Given this list of marker genes IL12B, ADAMTS12, CADM4, HRG, PIK3CB, MIR199A1, DAB2IP, ANGPT1, SPRY2, MIR16-1, ATP2B4, MIR342 (NCBI Gene Id 442909), MIR424, IL12A, EMILIN1, MIR329-1, SEMA6A, DCN, ADGRA2, NR2F2, here is a description of the gene set: studied in species Homo sapiens Human Gene Set: GOBP_NEGATIVE_REGULATION_OF_CELLULAR_RESPONSE_TO_VASCULAR_ENDOTHELIAL_GROWTH_FACTOR_STIMULUS Any process that stops, prevents or reduces the frequency, rate or extent of cellular response to vascular endothelial growth factor stimulus.